Given this list of marker genes ANKH, LRRC8E, SLC25A51, ABCC4, SLC25A47, LRRC8C, SLC25A42, SLC46A2, SLC35B3, SLC25A23, P2RX7, ADCY10, CALHM5, ABCC11, CALHM3 (NCBI Gene Id 119395), SLC25A17, SLC35B1, SLC25A4, SLC25A5, SLC35B2, LRRC8D, LRRC8A, ABCC5, CALHM4, SLC25A53, CALHM2 (calcium homeostasis modulator family member 2), SLC25A6, SHOC2, SLC25A24, CD47, SLC25A31, SLC25A25 (NCBI Gene Id 114789), CR1, ABCC6, PANX1, CALHM6, SLC25A52, SLC25A41, SLC19A1, LRRC8B, CALHM1, SLC17A9, here is a description of the gene set: species: Homo sapiens Human Gene Set: GOBP_PURINE_NUCLEOTIDE_TRANSPORT The directed movement of a purine nucleotide, any compound consisting of a purine nucleoside esterified with (ortho)phosphate, into, out of or within a cell.